The following is a description of a gene set: Human Gene Set: DESCARTES_FETAL_SPLEEN_MESOTHELIAL_CELLS The gene expression program underlying the specification of human cell types is of fundamental interest. The study authors generated human cell atlases of gene expression and chromatin accessibility in fetal tissues. For gene expression, the study authors applied three-level combinatorial indexing to >110 samples representing 15 organs, ultimately profiling ~4 million single cells. The study authors leveraged the literature and other atlases to identify and annotate hundreds of cell types and subtypes, both within and across tissues. Our analyses focused on organ-specific specializations of broadly distributed cell types (such as blood, endothelial, and epithelial), sites of fetal erythropoiesis (which notably included the adrenal gland), and integration with mouse developmental atlases (such as conserved specification of blood cells). These data represent a rich resource for the exploration of in vivo human gene expression in diverse tissues and cell types. from publication Cao J, O'Day DR, Pliner HA, Kingsley PD, Deng M, Daza RM, Zager MA, Aldinger KA, Blecher-Gonen R, Zhang F, Spielmann M, Palis J, Doherty D, Steemers FJ, Glass IA, Trapnell C, Shendure J (PMID 33184181) Marker genes curated from the annotated cluster as represented in the Descartes Human Gene Expression During Development database. studied in species Homo sapiens, and this is the list of marker genes: IL6, CCN3, NPHS1, SMTNL2 (NCBI Gene Id 342527), ATF3, ILDR2, UPK3B, B3GALT1, REEP1, COL8A1, LINGO2 (NCBI Gene Id 353298), LHX9, DUSP1, ARHGAP44, ISL1, KRT18, GADD45A, IGSF9, FENDRR, AHNAK2, RGS16, MCOLN3, DSG2, RRAD, MUC16, CSDC2, CHRDL1, PPL, GFPT2, CGN, RSPO1, KLK11, ID4, HSPB2, JUNB, PROCR, RSPO3, GADL1, OGN, ADIRF, AOX1, EZR (ezrin), CDH3, PPP1R15A, FMN2, GLP2R, SPOCK2, GPNMB, NEBL, S100A10, NPNT, PTPRQ, MGP (matrix Gla protein), SH3RF2, FAM83H, FLRT3, KCTD8, HSPA1B, TNNT1, OLR1, CDKN1A, GJA1 (NCBI Gene Id 7953), CHRM2, SEMA3C, HAND2, SLPI, BMP3, EFNB3, BASP1-AS1, WNT5A, KRT5, GAS1, INMT, TMEM151A, CXADR, PTGIS, FOS, MSLN, NXPH2, TNFSF9, CA11, NDRG1, TIMP1, ADAMTSL4, CLIC3, CGNL1, MMP24, ARSJ, PDPN, BNC2, ANKRD50, SLC34A2, CFAP210, TGM1, ITPKC, GAS1RR, EFEMP1, CAPN6, CTXN1, C19orf33, SMPD3, PCDHA6, PLAT, NEK5, CBLN2, NR2F1, ITGA3, DSC3, IER3, IQUB, SULF1, PDGFRL, SFRP2, PDZK1IP1, SOCS3, CDON, REC8, SCNN1A, HHIP-AS1, SLC4A4, MTMR7, RASSF7, LGI2, NREP, BNC1, WNT2B, TPD52L1, ADGRL3, TGFB3, GRIN2A, FGF18, BMP4, TM4SF1, CRIP1, LINC01099, CSRNP1, CARNS1, FAM167A, FGF9, LRRTM1, FZD7, LAMA5, EGR1, HAS1, ADAMTS8, INSYN1, ADAMTS5, QRFPR, KRT19, NRG4, ADAMTS15, PLA2G2A, CRB2, GLT8D2, RNF217-AS1, EGFL6, ANO5, TUFT1, KRT8, NFASC, ARFGEF3, SBSPON (somatomedin B and thrombospondin type 1 domain containing), PATJ, MYRF, SGIP1, KLF5, CLDN15, SGO2, PPP1R3B, LRP2, HHIP, PAPPA (pappalysin 1), LRRN4, VAT1L, OMD, MAL2, F3, LGALS3 (galectin 3), WWC1 (NCBI Gene Id 23286), KRT7, B3GALT2, EPHB6, ANXA1, FOXF1, PRG4, MAF, ELAVL2, ZFP36, CYSTM1, CEP170B, FABP4, SEMA3D, EPCIP, BHLHE40